The following is a description of a gene set: Human Gene Set: KEGG_MEDICUS_REFERENCE_ITGA_B_RHOGAP_RHOA_SIGNALING_PATHWAY Pathway Definition from KEGG: FN1 -> (ITGA+ITGB) -> SRC -> ARHGAP35 -| RHOA ITGA/B-RhoGAP-RhoA signaling pathway. Pathway ID: N00393. Pathway type: Reference. Pathway class: nt06167 Human cytomegalovirus (HCMV). studied in species Homo sapiens, and this is the list of marker genes: ARHGAP35, ITGB5, ITGA11, ITGA1, ITGB6, ITGA8, SRC, ITGA10, ITGA4, ITGB8, RHOA, ITGB1, ITGA5, ITGAV, ITGB7, ITGA7, ITGB3, ITGA2B, ITGB4, ITGA9, ITGA2, ITGA3, FN1